Given this list of marker genes COX7A2L, BRD3OS, COIL, BAG5, GMFB, XPA, EIF2B2, PARG, NFATC2IP, MARCHF7, POLR3C, DNPEP, PDCD10, TBPL1, SPCS2 (signal peptidase complex subunit 2), PRPF18, CNBP, WIPI2, TERF2IP, PPP2R5E, FAF2, PRPSAP1, PRPF4, PPP1R7, ZNF410, SMAD2, KBTBD2, RAB11A, ATXN2, PEX11B, DUSP11, HTATSF1, PSMD10, UBR5, STXBP3, TOR1AIP1, SCRIB, UBE2A, ILVBL, IK, URI1, SDHC, NUP88, TPR, ZZZ3, GTF2H1, XPC, DPM1, CUX1, RAE1, TBCB, PSMA5, OARD1, ARCN1, UFD1 (NCBI Gene Id 7353), SEC22B, ZNHIT3, CFDP1 (NCBI Gene Id 10428), NUBP1, PSMC2, here is a description of the gene set: Human Gene Set: MORF_RAB11A species: Homo sapiens Neighborhood of RAB11A Neighborhood of RAB11A RAB11A, member RAS oncogene family in the MORF expression compendium